The following is a description of a gene set: species: Mus musculus Mouse Gene Set: MIR_1191A Genes predicted to be targets of miRBase v22 microRNA mmu_miR_1191a in miRDB v6.0 with MirTarget v4 prediction scores > 80 (high confidence targets). from publication Chen Y, Wang X (PMID 31504780), and this is the list of marker genes: Kif23, Evx2, Dach1, Id2, Cyrib, Cbll1, Kcnn2, Ncor1, Msr1, Tef, Igfbp7, Ing2, Pwwp2a (NCBI Gene Id 70802), Gria2, Sytl2, Syne2, Cycs, Kpna3, Aipl1, Phf1, Pnpo, Fcrla, Pnrc2, Dut, Thsd7a, Tceanc, Exoc5, Ppm1k, Dmwd, Bmp7, Pld5, Slc9a7, Prkca, Pnisr, Zfp563, Tmem170b, Cnst, Ddx19b, Ugp2, Zfp93, Usp14, Tbl1xr1, Lix1l, Dclk1, Gpr61, Srbd1, Igf2r (NCBI Gene Id 16004), Rap2b, Zfp423 (NCBI Gene Id 94187), Npy5r, Prpf38b, Grxcr2, Srpra, Luc7l3, Ints10 (integrator complex subunit 10), Aplp2, Slc12a2, Vsig10